The following is a description of a gene set: species: Mus musculus Mouse Gene Set: GOMF_ADENYLATE_CYCLASE_BINDING Binding to an adenylate cyclase., and this is the list of marker genes: Akap5, Adrb2, Akap6, Adcyap1r1, Calm1, Adcy2, Raf1, Calm2, Adcy5, Akap12, Cap1, Chrna7, Cap2, Calm3, Gria1, Rps23rg1